The following is a description of a gene set: A lighter than expected T2 signal on magnetic resonance imaging (MRI) of the brainstem. This term refers to a localized hyperintensity affecting a particular region of the brainstem. studied in species Homo sapiens Focal T2 hyperintense brainstem lesion Human Gene Set: HP_FOCAL_T2_HYPERINTENSE_BRAINSTEM_LESION, and this is the list of marker genes: NUBPL, NDUFA1, NDUFS1, MT-ND2, PIK3CA, TIMMDC1, MT-ND3, KRIT1, NDUFS7, NDUFB3, NDUFS6, CCM2, FOXRED1, NDUFAF3, NDUFA11, NDUFB11, NDUFAF5, NDUFB9, NDUFAF2, NDUFV2, NDUFS2, NDUFB10, NDUFAF8, NDUFS8, PDCD10, TMEM126B, NDUFAF1, NDUFAF4, ATP7B, NDUFS3, NDUFA6, NDUFS4, MT-ND1, NDUFV1 (NADH:ubiquinone oxidoreductase core subunit V1)